Given this list of marker genes Dgat2, Awat2, Dgat2l6, Dgat1, Pnpla2, Pnpla3, Mgll, here is a description of the gene set: species: Mus musculus Acyl chain remodeling of DAG and TAG Mouse Gene Set: REACTOME_ACYL_CHAIN_REMODELING_OF_DAG_AND_TAG